The following is a description of a gene set: studied in species Mus musculus The process in which an angiotensin-mediated signaling system present in the brain regulates the force with which blood passes through the circulatory system. Mouse Gene Set: GOBP_BRAIN_RENIN_ANGIOTENSIN_SYSTEM, and this is the list of marker genes: Rps6ka2, Agt, Klk1b26, Agtr1b, Agtr1a, Ace2 (NCBI Gene Id 70008), Tacr1, Agtr2